The following is a description of a gene set: species: Homo sapiens Human Gene Set: chr5p13, and this is the list of marker genes: CAPSL-DT, TTC23L, LSP1P3, TARS1-DT, ENSG00000296733, AIG1P1, MTHFD2P6, MIR3650, ENSG00000303861, SLC1A3, CARD6, CPLANE1, EGFLAM-AS2 (EGFLAM antisense RNA 2), GUSBP18, LINC02104, RAI14, RNU7-75P, LINC02064, OFD1P17, TTC23L-AS1, RXFP3, LIFR, SLC45A2, RNU7-130P, HPRT1P2, LMBRD2, OSMR-DT, RN7SL37P, SNORA63, LINC00604, SKP2, RNU6-358P, RAD1, ZCCHC10P2, PRKAA1, C1QTNF3, CPLANE1-AS1, CDH6, AMACR, LINC02120, ADAMTS12, NUP155, C9, SLC1A3-AS1, RNU6-760P, RAI14-DT, UGT3A2, MIR4279, RIMOC1, NIPBL, TMEM183AP2, ENSG00000297849, NADK2-AS1, TARS1, NADK2, RNU6-1305P, RBISP2, GDNF-AS1, DAB2, ENSG00000287597, GOLPH3-DT (NCBI Gene Id 118597838), SERBP1P6, RICTOR, KRT18P56, SNORD72, SUB1, C7, SUCLG2P4, GDNF, CFAP53P1, ENSG00000201368, PRLR, GOLPH3, SPEF2, GCSHP1, ENSG00000300362, PTGER4, TOMM40P3, MTMR12, DUX4L51, OSMR, MIR579, ENSG00000215156, LINC02996, KCTD9P5, DROSHA, NPR3, FHP2, EGFLAM-AS4, NIPBL-DT, UBL5P1, RPSAP38, EGFLAM-AS3, INTS6P1, RPL5P14, RNU6-484P, PLCXD3, LINC02160, RPL21P56, RPL37, RPS4XP6, RNU6-1190P, GOLGA5P1, TPT1P5, FBXO4, AGXT2, LINC02061, RPL21P54, UGT3A1, LINC00603, FYB1, RNA5SP181, IL7R, PDZD2, TTC33, DNAJC21, RN7SKP207, MIR580, LIFR-AS1, EGFLAM, RNU6-923P, GHR, MROH2B, OXCT1-AS1, KRT18P31, OXCT1, RNU1-150P, WDR70, ZFR, BRIX1, RNU6-378P, RNU6-1079P, C5orf22, RNU7-161P, ENSG00000298475, EGFLAM-AS1, C6, RPL19P11, C1QTNF3-AMACR, CAPSL, RANBP3L, RNU6-363P, LINC02117 (NCBI Gene Id 105374728)